The following is a description of a gene set: Any process that modulates the frequency, rate or extent of interleukin-1-mediated signaling pathway. species: Homo sapiens Human Gene Set: GOBP_REGULATION_OF_INTERLEUKIN_1_MEDIATED_SIGNALING_PATHWAY, and this is the list of marker genes: IL1R2, PYDC1, IL1R1, IL1RN, IL6, MIR21, MIR27A, TAX1BP1, ZBP1 (Z-DNA binding protein 1), ZNF675, SIGIRR, OTUD4, VRK2